Given this list of marker genes FOXF2 (forkhead box F2), TRHDE, PLPP3, GEM, SERPINE2, ITPRIP, SIRPG, RHEBL1, DNAI7, ACSL4, WNT8A, CLEC3A, SIPA1, GPR157, TMEM74B, CDKL2, FSTL1, ZNF804B, KLF11, GAL3ST4, DNAH2, PLP2 (NCBI Gene Id 5355, proteolipid protein 2), GNB3, MN1, CRACD, LINC02523, SH2D3C, RHOB, STK3 (serine/threonine kinase 3), RFX2, DNMBP, TMSB15A, HTR3B, ISX, ALKAL2, GPC5, TNFRSF4 (TNF receptor superfamily member 4), PHLDB3, CYP2A7P1, AP5B1, LINC00710, TRAM2, RRH, IL15RA, LINC01539, TMEM35A, CFD, TTTY13, DDAH2, PPP1R17, DRAM1, ARL5C, INSIG1, SPMIP3, SMR3B, NTRK1, KCNN4, LINC01091, AGPAT4, FRZB, TTL, ICOSLG, CPT1A, RBPMS2, GABBR1, B3GNT2, FAM89A, KCNG3, L1CAM, ISM1, YIPF5, CXXC5, LRRC2-AS1, NXF3, DUSP1, TMEM170B, IGSF11-AS1, DDX19A-DT, SAGE1, PLAUR, MSMB, WDTC1, IL6R, ENTPD5, SPINK5, C22orf31, GCNA, GSTT4, NINJ1, MAFF, PTPN9 (NCBI Gene Id 5780), LINC02520, PJA2, KIF7, AQP10, DDIT4, RBKS, CFAP418, FBXO31, CD5L, COLEC12, LINC01118, LHFPL6, KCNA2, INSL5, MYH6, EFCAB10, ID3, NUP62CL, SORBS2, HIVEP3, LINC00629, IGHD, IL23R, NTS, S1PR3, COL6A3, ST6GAL2, BSPRY, PPARGC1B, DUSP15 (NCBI Gene Id 83747), ENC1, ENSG00000291065, LINC01121, OSBPL3, TYSND1, L2HGDH, PRSS12, NEDD9, DCUN1D4, EMP1, NCKAP5L, FOSL1, VPS37A, DUSP4, GPC3, RHOU, ADRA2A, ZFPM2, DEFB122, MRPL1, LINC00174, SPAG9 (sperm associated antigen 9), CILP2, OR6A2, PLEK2 (pleckstrin 2), UGT8, LMX1B (LIM homeobox transcription factor 1 beta), DUSP5, TLE3, ARRDC3, HPD, ASIC5, NPTX1, SLC17A8 (solute carrier family 17 member 8), HS1BP3, SLC22A18AS, IL6, FABP5, GDF3, SH3RF3, LRRC75A, PFN4, NLRP3, ST7-AS2, FOXN4, ZBTB8B, TRIM64EP, BCR, OR10C1, GFOD1, GCNT7, EFNA1, GADD45A, ENSG00000282375 (novel transcript), EIF5A2, GTF3C2-AS1, STARD8, RGS3, TMEM121B, PDCD1, EDA2R, CHRM1, IFNAR2, LAMB1, ODF2, HCG18, GIMAP8, SPZ1, PPM1L, here is a description of the gene set: Genes down-regulated in comparison of CD4 T cells treated with IL4 and anti-IL12 at 2 h versus the untreated cells at 2 h. from publication Elo LL, Järvenpää H, Tuomela S, Raghav S, Ahlfors H, Laurila K, Gupta B, Lund RJ, Tahvanainen J, Hawkins RD, Oresic M, Lähdesmäki H, Rasool O, Rao KV, Aittokallio T, Lahesmaa R (PMID 20620947) Human Gene Set: GSE17974_IL4_AND_ANTI_IL12_VS_UNTREATED_2H_ACT_CD4_TCELL_DN The aim of this dataset was to study in detail the transcription kinetics initiated by cytokine IL-4 in early differentiation of Th2 cells. species: Homo sapiens